The following is a description of a gene set: from publication Kaji T, Ishige A, Hikida M, Taka J, Hijikata A, Kubo M, Nagashima T, Takahashi Y, Kurosaki T, Okada M, Ohara O, Rajewsky K, Takemori T (PMID 23027924) species: Homo sapiens Genes up-regulated in marginal zone B lymphocytes: wildtype versus heterozygotic knockout of BCL6. Bcl6 germline deletion causes a prominent inflammatory disease, owing to over-expression of Th2 cytokines, and affects the properties of B cells prior to immunization. Therefore we established the B cell-specific Bcl6 deletion mice and analyze the gene expression of naive B cells under physiological conditions. Human Gene Set: GSE28737_WT_VS_BCL6_HET_MARGINAL_ZONE_BCELL_UP, and this is the list of marker genes: RTN1, FGFBP1, ISLR2, FYB1, TRIM7, GPRC5B, TWF2, PLBD1, ABCA5, PADI3, NSA2, FBRSL1, CACNG8 (calcium voltage-gated channel auxiliary subunit gamma 8), E4F1, CHD8, VPS37C, AMZ1, KLHL24, PARD6G, TOP2B, DKK3, MOGAT2, UCHL1, CD79B, NCF2, PSME3IP1, ARR3, SNAI1, SLC2A4RG, MAK16, ARMC7, ATF7IP, NME4, CYB561A3, NTPCR, MACROH2A2, COG7 (NCBI Gene Id 91949), DEPTOR, OTUD5, DYNC2LI1, DHRS3, CCM2, RPL24, ALDOB, TMEM141 (transmembrane protein 141), FAT1, KCTD14, PEMT, ZNF652, BORCS8, PXMP4, ING3, CTNND2, RPS6KA2, DHRS7, LPXN, TIFAB, ZNF704, RING1, P3H2, GLI1, ALPK1, METTL18, IFT25, ZNF585A, CD5, FOXO1, IL6ST, BCS1L (NCBI Gene Id 7856), TIRAP, BAAT, HAND2, PLEKHM3, CDC26, HEPACAM2, HARBI1, NMNAT1, FES, IFT81, ITLN1, ARPC5L, CYGB, CCNDBP1, THNSL2, SELENBP1, UQCC5, MTIF3, CACNG2, NUDT7, AFG1L, PRKAB2, NUDT14, SLC16A13, CWF19L1, CCDC28A, CLEC4G, IFT57, ITPRIPL2 (ITPRIP like 2), MAP2K6, FBXO32, VAMP2, PDSS2, STAB1 (NCBI Gene Id 23166), LCA5L, BAIAP2, ZNF606, SALL3, MDP1, SMIM3, AMMECR1L (NCBI Gene Id 83607), TRUB2, SLC66A2, ZNF804A, FAM210B, LHFPL3, CD276, C19orf67, PIP4P1, DDR1, MECR, FAM234A, LEPROTL1, BEX4, RWDD2A, HAO2, DYNLT4, UCKL1 (uridine-cytidine kinase 1 like 1), HMGN5, LIPT1, TERF2IP, FHIP1B, FGFR1, CX3CR1, CCDC107, TAF3, EXT2 (exostosin glycosyltransferase 2), GLUL, SELENON, THAP11, GPATCH2, SPATA13, BET1, CFAP90, SETD1B, SUMO3, LDAF1, SOS2, KIZ, METTL5, PLD4, VHL, TMEM234, GPSM3, HOXD8, NPL, AGFG2, GOLGA7, TMEM72, INIP, C1orf174, IRAG1, PDE7A, OXR1, LTBP2, DUS2, ENPP5 (NCBI Gene Id 59084), MAN2B2, FAU, SPMIP8, ERN1, SLC25A35, FCER1A, TMCO6, INPPL1, PRSS41, HGSNAT, SOX4, VPREB3, ATG4B, ZNF398, RIPOR2, CST11, B9D2, TMT1A, GMPPA, AKIRIN1, ACSS1, MAD1L1, CYP26A1, DTNB, MMP3, GSE1, RPL18, SMARCAL1, ARHGAP45, PLP2, GMFG, DROSHA, TTC23L, SAMD9L